Given this list of marker genes SLX1B, XRCC5, TERF2, SLX1A (NCBI Gene Id 548593), RTEL1, ERCC1, SLX4, here is a description of the gene set: Human Gene Set: GOBP_REGULATION_OF_T_CIRCLE_FORMATION species: Homo sapiens Any process that modulates the frequency, rate or extent of t-circle formation.